The following is a description of a gene set: Human Gene Set: GSE20715_WT_VS_TLR4_KO_48H_OZONE_LUNG_UP We previously identified toll-like receptor 4 (Tlr4) as a candidate gene responsible for ozone (O3)-induced pulmonary hyperpermeability and inflammation. The objective of this study was to determine the mechanism through which TLR4 modulates O3-induced pulmonary responses and to utilize transcriptomics to determine TLR4 effector molecules. C3H/HeJ (HeJ; Tlr4 mutant) and C3H/HeOuJ (OuJ; Tlr4 normal), mice were exposed continuously to 0.3 ppm O3 or filtered air for 6, 24, 48 or 72 hr. Affymetrix Mouse430A_MOE gene arrays were used to analyze lung homogenates from HeJ and OuJ mice followed using a bioinformatic analysis. Inflammation was assessed by bronchoalveolar lavage and molecular analysis by ELISA, immunoblotting, and transcription factor activity. TLR4 signals through both the MYD88-dependent and independent pathways in OuJ mice, which involves MAP kinase activation, NF-kappaB, AP-1, and KC. Microarray analyses identifiedTLR4 responsive genes for strain and time in OuJ versus HeJ mice (p<0.05). One significantly upregulated cluster of genes in OuJ were the heat shock proteins (Hspa1b; Hsp70), Hsp90ab1). Furthermore, O3-induced expression of HSP70 protein was increased in OuJ compared to HeJ mice following 24-48 h O3. Moreover, BAL polymorphonuclear leukocytes (PMN) and total protein were significantly reduced in response to O3 in Hspa1a/Hspa1btm1Dix (Hsp70-/-) compared to Hsp70+/+ mice (p<0.05). TLR4 signaling (MYD88-dependent), ERK1/2, AP-1 activity, and KC protein content were also significantly reduced after O3 exposure in Hsp70-/- compared to Hsp70+/+ mice (p<0.05). These studies suggest that HSP70 is involved in the regulation of O3-induced lung inflammation through the TLR4 pathway and provide evidence that HSP70 is an endogenous in vivo TLR4 ligand. Genes up-regulated in comparison of lung tissue from wild type mice subjected to ozone for 48 h versus that from TLR4 deficient mice subjected to ozone for 48 h. from publication Bauer AK, Rondini EA, Hummel KA, Degraff LM, Walker C, Jedlicka AE, Kleeberger SR (PMID 21543283) studied in species Homo sapiens, and this is the list of marker genes: NKX2-2, FKBP5 (FKBP prolyl isomerase 5), ADRA1B, ID1, ATG7, SGCE, WIPI2, EXD2, PER2, SARAF, ENO3, FXR1, VIM, TMT1A, PALS1, GJA3, PJA1, TWSG1, E2F6, FIG4, WLS, GZMA, CEBPD, SERINC1, AXL, HGFAC, IL16, AKIRIN1, C5orf24, SEMA3B, SLC29A1, FLYWCH2, RAB18, SNX3, RIMOC1, MAGI3, SH2D3C, PSMC3IP, RAPGEF4, PPP2CB, HSPH1, DCLRE1A, ATRN, DEDD2, PRKCH, TMOD3, CASP9, OVOL2, AHSA1, CRY2, CLSTN2, PRP4K, IL1RN, FMO2, HHIP, MKRN2, SLC25A24, MEF2A, FBXO32, TAGLN2, SGMS1, RUSC2 (NCBI Gene Id 9853), LTBP4, LDLRAD4, GUCY1A1, S1PR1, SOBP, CADM1, DNAJB1, NEK1, LCE3B, EDNRB, C1QTNF12, FABP1, DNAJB4 (DnaJ heat shock protein family (Hsp40) member B4), GUCY1B1, ADAM28, PRELP, SCG3, CLCN1, STIP1, GGA2, SOX3, FRMD8, SELENOV, ANGPTL2, STAMBP, BHLHE23, FANCL, GABRR2, PLBD2, VTN, COX19, DUSP1 (dual specificity phosphatase 1), ARL4A, TCF12 (transcription factor 12), CD302, ARL6IP6, CYP2A6, RCL1, PLOD1, ZIM3, RAP1GAP, CAST, HOMER1, NIBAN1, CACYBP, COPZ2, CMYA5, STIM1, ABCF2 (ATP binding cassette subfamily F member 2), TBX4, CEND1, CD3D, IVD, YIPF7, TSC22D3, SNX5, GMIP, USP29, PILRA, MR1, PER3, MECOM, VAX2, SNAP29, SLC7A10, TBP, SLC25A38, ITPRID2, GHRHR (growth hormone releasing hormone receptor), CACNG4, WEE1, ALDH1A1, HSPB1, SDHAF2, UCP2, DNAJA2, COL4A4, CLIC4, LMBR1, LIMS4, PPL, FXYD1, TCIM, DNAJA1, FUT7, UBE2L6, PAPOLA, CCT6A, CIDEC, HSPA1B, AMN, NOX4, ITGA8, SUV39H1, RAB43, PSEN1, ATP5F1B, NAA60, LHX1, ALAS1, LRAT, SEC14L2, NFE2L2, TWIST1, MAP3K6, AKT3, RSRP1, NDE1, RYBP, HLA-DRA, C16orf74, POSTN, ALK, PLEKHF2, LPIN1, LTC4S, NCR1 (NCBI Gene Id 9437), DTNA, SUPT4H1, KIF5A, FBXO3 (F-box protein 3), YJEFN3, MINDY3 (MINDY lysine 48 deubiquitinase 3), HSPA4L, NPNT, ESYT1, POLA1, PAG1, GPRC6A, MARK1, IKZF4, NDFIP1, PLPP3, CD2, USP2, GPRC5B, NDEL1, DCC